Given this list of marker genes Ube2l3, Rps27a, Ubb, Ube2e1, Ube2k, Ube2c, Ube2t, Ubc, Uba1, Ube2r2, Ube2q2, Uba52rt, Ube2s, Uchl3, Uba6, Ube2d2a, Ube2h, Usp9x, Ube2d1, Ube2g2, Otulin, Usp5, Ube2w, Usp7, Ube2b, Uba52, Ube2z, Cdc34, Ube2g1, Ube2e3, Ube2a, here is a description of the gene set: species: Mus musculus Synthesis of active ubiquitin: roles of E1 and E2 enzymes Mouse Gene Set: REACTOME_SYNTHESIS_OF_ACTIVE_UBIQUITIN_ROLES_OF_E1_AND_E2_ENZYMES